The following is a description of a gene set: Mouse Organogenesis Cell Atlas (MOCA) DE_gene_main_cluster.csv, fold.change>=1.5, qval<0.05, pval<0.05 from publication Cao J, Spielmann M, Qiu X, Huang X, Ibrahim DM, Hill AJ, Zhang F, Mundlos S, Christiansen L, Steemers FJ, Trapnell C, Shendure J (PMID 30787437) species: Mus musculus Mouse Gene Set: DESCARTES_ORGANOGENESIS_STROMAL_CELLS, and this is the list of marker genes: Tmem11, Dnajb6, Rnf2, Ercc8, Rfc3, Itga10, Klhl11, Fam83e, Tmem170, Psma3, Iqcb1, Wdr3, D16Ertd472e, Rps28, Rbbp6, Tcf15, Sf3a1, Nacc1, 2810013P06Rik, Asf1a, Timm17a, Ppm1d, 5330438D12Rik, Pcnp, Plscr2, Atg13, Zfp955b, Itpkc (NCBI Gene Id 233011), Sinhcaf, 4833439L19Rik, C1d, Gm11520, Poln, Gm36584, Ubqln1, Maml1, Srpra, Morf4l1, Polg2, Rtca, Cep95, Ggps1 (geranylgeranyl diphosphate synthase 1), Kcmf1, Snu13, Peli1 (pellino 1), Gpr137b-ps, Gabpa, Lsm3, Trp53bp2, Prpf40a, Kif19b, Zfp30, Zfp664, Septin1 (septin 1), Erh, Zfp647, Champ1, Ubxn7, Ing1, 9030624G23Rik, Srsf3, Hoxc11, Gabpb1, Taf7, Zfp84, Gorasp2, Hmgxb3, Gm12367, Pigx, Cand1, 5430405H02Rik, Nif3l1, Rrh, Arih1 (ariadne RBR E3 ubiquitin protein ligase 1), Sar1a, Ppp2r2a (protein phosphatase 2, regulatory subunit B, alpha), Sumo1, Gng5, Ercc3, Prps1, Cops4, Zswim4, Rnf114, 1700028N14Rik, Fam220a, Prpf6 (pre-mRNA splicing factor 6), Lig4, 4930532G15Rik, Arf4, Smn1, Tomm20, H2bc22, Orc1, 1810024B03Rik, Fbxo4 (NCBI Gene Id 67521), Ginm1, Rab5a, Prrc2c (proline-rich coiled-coil 2C), Prpf38a, Stpg4, Msh4, Morc2a, Chmp1b, Uba2, Exog, Limd1, Ppa1, Mcmbp, Mfsd9, 1190005I06Rik, Rsrc2, Gm22208, Gm16853, Terf2ip, Gpn1, Pfdn2, Zfp112, Kpna6, Fem1c, Arpc5l, Bcl2l11, Nup54, Golph3, Gm9828, Hnrnpll, Zfp623, Fscn1, Cry1, Tmem230, Zfp319, Opn3 (opsin 3), Appbp2, Trim45, Ints2, Nedd8 (NCBI Gene Id 18002), Yy1, Rdh14, Smndc1, Psen1, Polr2b, Lrrc41, Snapc5, Fbxo28, Ddx18, Oaz2, Gpn2, Ccdc186, Gm22786, Rtcb, Zbtb6, Slc10a1 (solute carrier family 10 (sodium/bile acid cotransporter family), member 1), Med10, Pip5k1a, Phlpp2, Ammecr1l, Ints12, Zfp212, Spmap1, Nmral1, Sirt1, Snrpa, Rbm27, 9430037O13Rik, Med13, Smcr8, Ube2a, Csnk1d, Spryd4, Mycbp, Ddx3x, Gm30238, Zfp326 (zinc finger protein 326), Gm7972, Tnpo1, N4bp2os, Snx33, Snhg15, Bri3, Togaram1, Orc4, Rpl36, Zbtb2, Mex3c, Gpbp1l1, B130021K23Rik, Fbxo30, Lrrc75aos2 (NCBI Gene Id 66829), Zc3hc1, 2010320M18Rik, Ppp1cb, Khdrbs1, Pcf11, Fstl3, Gfpt2, Nrde2, Atg14, Rpl9, Coa7 (cytochrome c oxidase assembly factor 7), Ddx6, Wdr18, Clcn1, Rps4x, Dtl, Rpl35a, Fbxo21, Pank3, Avil, Thop1, Jmjd4, Ddx52, Rrp36, Smad4, 4930413G21Rik, Fam53c, Ahcyl1, Cbll1, Rbbp4, Gm17529, Unkl (unkempt family like zinc finger), C430039J01Rik, Msh2, Dynlt2b, Zfp1006, Ythdc1, Cnot6